The following is a description of a gene set: Reactome Pathway: SARS-CoV-2 Genome Replication and Transcription part of: Early SARS-CoV-2 Infection Events species: Homo sapiens This COVID-19 pathway has been created by a combination of computational inference from SARS-CoV-1 data (https://reactome.org/documentation/inferred-events) and manual curation, as described in the summation for the overall SARS-CoV-2 infection pathway. Specifically, binding of the replication-transcription complex (RTC) to the RNA template and the polymerase activity of nsp12, helicase activity of nsp13, capping activity of nsp16, and polyadenylation of SARS-CoV-2 genomic RNA and transcripts have been studied directly, and the remaining steps have been inferred from previous studies in SARS-CoV-1 and related coronaviruses.<br><br>Using the genomic RNA as a template, the coronavirus replicase synthesizes full-length negative-sense antigenome, which in turn serves as a template for the synthesis of new genomic RNA. The polymerase can also switch template during discontinuous transcription of the genome at specific sites called transcription-regulated sequences, thereby producing a 5'-nested set of negative-sense sgRNAs, which are used as templates for the synthesis of a 3'-nested set of positive-sense sgRNAs. Although genome replication/transcription is mainly mediated by the viral replicase and confines in the RTC, the involvement of various additional viral and host factors has been implicated. For instance, coronavirus N protein is known to serve as an RNA chaperone and facilitate template switching. Importantly, the N protein of SARS-CoV-1 and mouse hepatitis virus (MHV-JHM) is also phosphorylated by the host glycogen synthase kinase 3 (GSK3), and inhibition of GSK3 was shown to inhibit viral replication in Vero E6 cells infected with SARS-CoV-1. Additionally, GSK3-mediated phosphorylation of the MHV-JHM N protein recruits an RNA-binding protein DEAD-box helicase 1 (DDX1), which facilitates template read-through, favoring the synthesis of genomic RNA and longer sgRNAs. Another RNA-binding protein called heterogeneous nuclear ribonucleoprotein A1 (hnRNPA1) can also bind tightly to SARS-CoV-1 N protein and potentially regulate viral RNA synthesis. Host RNA-binding proteins could also bind directly to untranslated regions (UTRs) of the coronavirus genome to modulate replication/transcription, such as zinc finger CCHC-type and RNA-binding motif 1 (ZCRB1) binding to the 5-UTR of IBV, mitochondrial aconitase binding to the 3' UTR of MHV, and poly(A)-binding protein (PABP) to the poly(A) tail of bovine coronavirus. For review, please refer to Snijder et al. 2016 and Fung and Liu 2019., and this is the list of marker genes: VHL (NCBI Gene Id 8056), RB1, rep, pp1a, SARS coronavirus, complete genome, N, ZCRB1, DDX5